The following is a description of a gene set: Genes down-regulated in MEF cells (embryonic fibroblasts) from PARP1 knockout mice. Human Gene Set: SIMBULAN_PARP1_TARGETS_DN studied in species Mus musculus from publication Simbulan-Rosenthal CM, Ly DH, Rosenthal DS, Konopka G, Luo R, Wang ZQ, Schultz PG, Smulson ME (PMID 11016956) Poly(ADP-ribose) polymerase (PARP) is implicated in the maintenance of genomic integrity, given that inhibition or depletion of this enzyme increases genomic instability in cells exposed to genotoxic agents. We previously showed that immortalized fibroblasts derived from PARP(-/-) mice exhibit an unstable tetraploid population, and partial chromosomal gains and losses in PARP(-/-) mice and immortalized fibroblasts are accompanied by changes in the expression of p53, Rb, and c-Jun, as well as other proteins. A tetraploid population has also now been detected in primary fibroblasts derived from PARP(-/-) mice. Oligonucleotide microarray analysis was applied to characterize more comprehensively the differences in gene expression between asynchronously dividing primary fibroblasts derived from PARP(-/-) mice and their wild-type littermates. Of the genes monitored, 91 differentially expressed genes were identified. The loss of PARP results in down-regulation of the expression of several genes involved in regulation of cell cycle progression or mitosis, DNA replication, or chromosomal processing or assembly. PARP deficiency also up-regulates genes that encode extracellular matrix or cytoskeletal proteins that are implicated in cancer initiation or progression or in normal or premature aging. These results provide insight into the mechanism by which PARP deficiency impairs mitotic function, thereby resulting in the genomic alterations and chromosomal abnormalities as well as in altered expression of genes that may contribute to genomic instability, cancer, and aging., and this is the list of marker genes: CCNB1, STMN1, CDC20, SPP1, TAGLN2, H2AC8, PRIM1, HMGB2, CCNB2, CCNA2, IGFBP5, SERPINH1, SET, PCNA, DNMT1, RANGAP1, UBE2S